Given this list of marker genes PDCD1, HSH2D, MIF, BCL6, AURKB, NOC2L, SLC39A10, ADA, BCL2, CD74, IRS2, FOXP1, ORMDL3, BCL10, MIR17HG, IL2, here is a description of the gene set: Human Gene Set: GOBP_NEGATIVE_REGULATION_OF_B_CELL_APOPTOTIC_PROCESS species: Homo sapiens Any process that stops, prevents, or reduces the frequency, rate, or extent of B cell apoptotic process.